The following is a description of a gene set: studied in species Homo sapiens from publication Orabona C, Puccetti P, Vacca C, Bicciato S, Luchini A, Fallarino F, Bianchi R, Velardi E, Perruccio K, Velardi A, Bronte V, Fioretti MC, Grohmann U (PMID 16339401) Although much is known on the transcriptional profiles of dendritic cells (DCs) during maturation, the molecular switches critical for the acquisition of a tolerogenic program by DCs are still obscure. In the present study, we explored the gene expression pattern of CD8+ DCs purified from the mouse spleen and treated with interferon (IFN)-gamma. The cytokine, indeed, potentiates the tolerogenic potential of this DC subset via induction of the immunosuppressive tryptophan catabolism mediated by indoleamine 2,3-dioxygenase (IDO). By comparing the expression of the IFN-gamma-modulated genes in IDO+ versus IDO- murine DCs, we found a consistent and selective association of the IDO-competent phenotype with the down-modulation of the Tyrobp gene, encoding the adapter molecule DAP12. IFN-gamma-mediated down-modulation of this gene involved IFN consensus sequence binding protein (ICSBP), a transcription factor also known as IRF-8. While silencing of Tyrobp conferred IDO functional competence on IDO- DCs, silencing of Icsbp1 in IDO+ cells completely abolished IDO expression and function. In parallel, silencing of TYROBP conferred IDO competence on human IDO- DCs while silencing of IRF8 impaired IDO expression and activity in human IDO+ DCs. Therefore, the same small set of molecular switches controls IDO competence in murine and human DCs. Genes down-regulated in comparison of untreated CD8+ dendritic cells (DC) at 4 h versus those treated with IFNG at 16 h. Human Gene Set: GSE3337_4H_VS_16H_IFNG_IN_CD8POS_DC_DN, and this is the list of marker genes: GMFG, LGALS1, HMOX1, ERP29, MSH5, SUMF1, SYS1, MAGEH1, FERMT3, PLAUR, LY6E, IGLC7, CCL2, MAP4K3, SRPK3 (SRSF protein kinase 3), PLXNB2, PLPP1, ID3, OSBPL5, PKIG, SURF1, LPP-AS2, CTSA, ARF5, ATP8A1, ENG, CSF3R, HLA-DMA, CTSV, SOAT1, DLX1, CSF1R, ICAM2, PPFIA4 (NCBI Gene Id 8497), IL18, HLA-DRB1, SLC25A53, AOAH, TMEM37, STIM1, CR2, CDIPT, COMT, PLD1, PHLDA3, ZP3, PELO, ETHE1, CD37, ARID3B, BST1, IFITM3, CD300C, POLD4, C6orf89, FLT4, SYCP3, CNDP2, NEK2, NRP1, KDELR1, SOX6, NUDT3, TUBB4A, LGALS3BP, FCER1G, SIPA1L2, HFE, TMEM268, FRRS1, CLEC4A, ZFR2 (zinc finger RNA binding protein 2), PLOD3, CLN3, ARL6IP1, GRN (NCBI Gene Id 2896), RPL22, CA14, VIPR2, CP, CDKN3, SALL4, ALDH2, GSTM5, ERF, SCG5, MAP3K5 (NCBI Gene Id 4217), AASS, OCM2, ACAA2, ALDOB, ITPR2, KCNAB2, CTSB (cathepsin B), PTPN18, HOPX, CLN8, AMPD3, PTPRE, HSD17B8, MPP1, TRAF3IP2, EMB, CD180, APOC2, STC1, PRKD2, MATK, RNF141, NUCB1, MAN2B1, BAK1, LPL, HLA-DOA, HEXA, AK3, EPN1 (NCBI Gene Id 29924), SYNJ2BP (synaptojanin 2 binding protein), HBG2, SMPD1, IFT88, IGKC, FCGR1A, MXD4, NT5DC3, SYK, BPHL, TXNIP, CD34, AADAT, PVT1, LIPA, H6PD, RPP21, IGF2BP1, SLC50A1, FKBP1B, NDUFA13, FADS1, CD5, SMAGP, SMDT1, LY86, ADGRE1, UCK1, LAMTOR4, C3, SLC10A2, TMEM234, CTBP2, PLD4 (phospholipase D family member 4), MEF2C, BSCL2, IGHM, STAB1, CD93, GRINA, TMEM160, NAPSA, GUCA1A, GABBR1, USP3, SFTPC, NLN, PSAP, TYROBP, GEMIN5, CYP24A1, SLC7A8, S100A1, FES, FOXD3 (NCBI Gene Id 373071), ARRB1, TBXAS1, ATG7, CD79B, RECQL5, MAFB, FCER2, SEPTIN9, CLIP3, HAGH, RNPEP, CCR6, SIT1, MR1, PIMREG, C1QB, ARHGAP9, HLA-DMB, SAG, ARPC5L, LYL1, DCTN5, GSN, ACOX1, RGS14, RGL2 (NCBI Gene Id 9264), HLA-DQA1, CD302